The following is a description of a gene set: Any cellular process that depends upon or alters the actin cytoskeleton, that part of the cytoskeleton comprising actin filaments and their associated proteins. studied in species Mus musculus Mouse Gene Set: GOBP_ACTIN_FILAMENT_BASED_PROCESS, and this is the list of marker genes: Magel2, Edn1, Nherf1, Itgb1, Espn, Mical3, Myrip, Rnf207, Prickle4, Wasf2, Kcne5, Mef2a, Was, Myh7b, Tgfb3, Nphs2, Ghrl, Spatc1l, Rflna, Adora1 (adenosine A1 receptor), Arpc5l, Pxn, Hck, Nkx2-5, Scn5a, Epdr1, Hip1, Emp2, Gja5, Rufy3, Neurl2, Zyx, Pdgfa, Shroom2, Lmod2, Cavin3, Mybpc1, Myo18a, Mtor, Rnd1, Pacsin2, Llgl1, Src, Cnn1, Pakap, Gdpd2, Trf (transferrin), Nck1, Add1, Cav3, Enah, Limk1, Serpinf2, Slit2, Sumo1 (NCBI Gene Id 22218), Ikbkb, Lmod3, Casq1, Ctnna3, Septin9, Kcnn2, Myh14, Ezr, Kcnj5, Vangl2, Nf2, Frmd6, Akap13, Bcas3, Myo9b, Sptbn2, Epha3, Brsk2, Myo5c, Cx3cl1, Klhl17, Shroom3, Scin, Pde4d (phosphodiesterase 4D, cAMP specific), Gas2l1, Tmod3, Capzb, Pi4ka, Pls1, Atxn3, Kcnh2, Gmfb, Cfl1, Tpm3, Fgf13, Arhgap35, Dlc1, Anxa1, Actr2 (NCBI Gene Id 66713), Ryr2, Rhod, Gja1, Pdlim3, Nphs1, Lcp1, Actn2, Hsp90b1 (NCBI Gene Id 22027), Abcc9, Tjp1, Elmo3, Arpc5, Kctd13, Hydin, Csf3, Myl2 (myosin, light polypeptide 2, regulatory, cardiac, slow), Fmnl3, Myo18b, Mrtfa (myocardin related transcription factor A), Ptger4, Ppm1e, Msrb1, Tenm1, Mypn, Insrr, Tmsb15l, Nckap1, Abracl, Rangrf, Gm14137, Sorbs1, Specc1, Scn1a, Pick1, Clasp2, Cyria, Vil1, Flnb, Gba2, Coro1b, Camk2d, Ccl26, Pcdh15 (NCBI Gene Id 623239), S100a9, Nup155, Tcap, F2rl1 (F2R like trypsin receptor 1), Capn1, Rnh1, Micall2, Cdc42ep4, Mfn2, Rhoh, Washc2, Kcna5, Sfrp1, Pdlim1, Spag6l, Ppargc1b, Wnt11, Cald1 (caldesmon 1), Farp2, Rap2a, Scn2b, Cryaa, Arhgef17, Slc9a1, Rnd2, Cyfip1, Clec2i, Cit, Arap3, Tpm1, Pycard, Itgb1bp1, Inppl1, Xirp2, Bst1 (bone marrow stromal cell antigen 1), Il1a, Rac3, Cdc42bpb, Spire1, Hcn4, Capza1, Myl6, Tnik (NCBI Gene Id 99639), Kank4, Dpysl3, Rdx, Kcne2, Pard3, Myo7b, Thsd7b, Myo1g, Aqp2, Lats1, Fhod3, Tesk1, Myo1c, Ppfia1, Pdgfb, Trpm4, Alkbh4, Syne2 (NCBI Gene Id 630548), Kras, Foxj1, Limk2, Taok1, Cdc42ep2, Acta1, Hrg, Itpka, Phactr4, Cdh1, Mtpn, Arpc3, Synpo (NCBI Gene Id 77694), Sema5a, S1pr2, Pak3, Wipf1, Cdk5, Frmd5, Cd47, Nck2, Cyrib, Arhgef15, Tmeff2, Abitram, Sptbn5, Dmtn, Tln2, Jup, Frmd3, Capza1b, Eln, Farp1, Rasa1, Cdk5r1, Kcne3, Myo3b, Tnnc1, Pdcl3, Tmsb15b2, Cxadr, Ep300, Sh2b2, Tagln2, Tmod4, Dsg3, Kptn, Pls3, Ppp1r9b, Prkce, Rala, Tmsb10, Clrn1, Ldb3, Kank1, Bmp10, Abra, Dixdc1, Eef2k, Plec, Scn3b, Mylk2, Avil, Myo15a (myosin XVA), Tnf, Tacr1, Tpm3-rs7, Amotl2, Dock2, Eps8, Pik3r2, Washc3, Gsn, Pdlim4, Wasf3, Kit, Naa80, Parvb (parvin, beta), Fscn2, Fam171a1, Arhgap40, Gata4, Pfdn1, Hcls1, Rhpn2, Cldn3, Setd3, Snta1 (NCBI Gene Id 99348), Pam, Actg1, Actn3, Sptbn4, Prkci, Prox1, Asap3, Pecam1 (NCBI Gene Id 97748), Asb2 (ankyrin repeat and SOCS box-containing 2), Lmod1, Myoz2 (NCBI Gene Id 80533), Myo1a, Arhgef10l, Dnaaf11, Ctnna2 (NCBI Gene Id 12548), Ran, Dsg2, Rictor, Pdgfra, Trim27, Mylk3, Sorbs3, Add2 (NCBI Gene Id 72970), Msrb2, S100a10, Plek, Iqgap3, Pak2, Arhgap18, Gas7, Gas2 (NCBI Gene Id 14453), Fermt2, Arfgef1, Nlrp5, Rhobtb2, Srcin1, Wdr1, Rock2, Daam2, Marcks, Kiss1r, Zbed3, Mir129-2, Synpo2l, Tacstd2, Xirp1, Bloc1s6, Sipa1l1, Pafah1b1, Myh8, Uty, Itgb5, Swap70, Cpne6, Myo5a, Cav1, Ccdc88a, Coro2b, Hax1, Myo1b, Gpd1l (NCBI Gene Id 72363), Rtkn, Ehd2, Mef2c, Rab13, Washc5, Glipr1l1, Epha1, Arfip2, Coro1c, Efna5, Fchsd1, Ooep, Epb41l3, Mtss1, Mical2, Mlst8, Bcl6, Nox4, Kcnq1, Nlrp4f, Zeb2, Hdac6, Frmd7, Ccl21f, Grb2, Cnn2, Kcne4, Stau2, Arhgef7, Dnajb6, Casp4, Csrp3, Atp1a2, Fam107a, Sh3gl2, Tyrobp, Cacna1d, Tesk2, Iqgap2, Pfn3, Ermn, Thsd7a, Mical1, Mad2l2, Arhgef19, Fgd1, Phldb2, Jam3, Braf, Fzd10, Cacna1h, Cdc42ep1, Capn3, Dbnl, Plek2, Capza2, Wipf3, Tnnt2, Rhoa, Trpv3, Ang, Nckap1l, Gpm6b, Tgfb2, Icam1, Shank3, Fgr, Frey1, Epb41l2, Aif1, Gas2l3, Arpc1a, Scn1b, Hmcn1, Trpm7, Dstn, Tle6 (transducin-like enhancer of split 6), Prkcd (NCBI Gene Id 52581), Prkd1, Sh3bp1, Sppl2c, Pik3r1, Myo1d, Rhoj, S1pr1, Dlg1, Cul3, Rflnb, Iqsec2, Pclo, Aqp1, Abi3bp, Nedd4l, Ccdc88c, Nf1, Rac1, Wasf1 (WASP family, member 1), Arpc4, Apoa1, Sdc4, Rgs4, Carmil2, Kbtbd13 (NCBI Gene Id 74492), Amotl1, Nrap, Lima1, Acap2, Kcne1, Arf6, Tnnt3, Cavin4, Adgrb1, Pln, C9orf72, Myh11, Limch1, Alms1, Ppm1f, Myo1e, Mrtfb, Actb, Strit1, Lix1l, Stard8, Ptger3, Cttn, Rgcc, Shc1, Ap1ar, Arhgef16, Bcr, Myom2, Baiap2l1, Pdcd6ip, Ift88, Rhov (NCBI Gene Id 228543), Trpv4, Evl, Cacna2d1, Cldn19, Tac1, Flna, Krt8, Actn1 (NCBI Gene Id 94278), Marcksl1, Csf1r, Mybpc3, Jmy, Frmpd4, Kank2, Bcl2, Flii, Gas2l2, Myoc, Pak1, Anln, Rhof, Tnfaip1, Nos1, Arhgef18, Adcy10, Abl2, Phpt1, Kash5, Met, Tpm2, Atp2c1, Dbn1, Ghsr, Rhob, Smap1, 4930544G11Rik, Vasp, Baiap2l2, Cacna1c, Ngef, Rnd3, Mob2, Hip1r, Trpm2, Carmil1, Sh3kbp1, Mybph, Svil, Capn10, Rhobtb1, Syde1, Nedd9, Atp2a2, Arap2, Nrp1 (NCBI Gene Id 270112), Prr5, Krt19, Twf1, Hras, Prkcq, Washc4, Coro7, Esam, Bcar1, Rhoc, Fscn3, Diaph2, Diaph3, Iqgap1, Ssh1, Srf, Inf2, Cracd, Epb41l1, Smad4, Myo7a, Flnc, Limd2, Iqsec1, Nebl (NCBI Gene Id 99452), Gpr65, Fchsd2 (NCBI Gene Id 97424), Ppp1r9a, Myl6b, Gmfg, Wmp, Sun2, Tsc1, Tmod2, Tpm4, Arhgap44, Pkp2, Pmp22, Elmo1, Agap2, Sele, Myo1f, Stmn1, Adprhl1, Smim22, Mink1, Spta1, Pkp3, Abi3, Prex1, Fhl3, Pawr, Ttc8, Siglec15, Kank3, Akap6, Nos1ap, Naa20, Crk (NCBI Gene Id 12928), Rap1gds1, Cdc42 (cell division cycle 42), Spire2, Bag4, Arhgap17, Fmn1, Amot, Fmn2, Sptan1, Cobl, Lpin1, Cap2, Pip5k1a, Plekhh2, Nisch, Prkn, Pik3ca, Catip, Specc1l, Kcnj8, Fat1 (NCBI Gene Id 76752), Atp1a1, Ttc17, Pdlim7, Kcnj2, Fnbp1l, Shroom1 (NCBI Gene Id 71774), Abl1, Rhoq, Myoz1, Dsc2, Ccl21b, Id1, Map3k1, Carmil3, Abr, Capg, Actc1, Sri, Tnnt1, Coro1a, Arap1, Cdc42bpa, Epb41, Arhgap6, Coro6, Atp2a1, Arpin, Ank2, Lurap1, Tnni3, Ptk2b, Epb41l4a, Sirpa, Ect2, Rhog, Plekhg2, Rhpn1 (rhophilin, Rho GTPase binding protein 1), Slc4a2, Tlr2, Whamm, Tgfbr1, Stard13, Mkks, Washc1, Myh9, Myadm, Dsp, Luzp1, Smad3, Cyfip2, Aif1l, Ptk7, Hdac2 (histone deacetylase 2), Srgap2, Cd2ap, Klhl41 (kelch-like 41), Cln3, Arhgef10, Abi2, Fhod1, Ophn1, Arpc1b, Myom3, Tmsb4x, Myo3a, Ccr7, Bst2, Trim32, Ccn2, Tln1, Calr, Dapk3, Arhgef26, Ilk, Elmo2, Mkln1, Rhou, Fhdc1, Samd14, Pfn5, Diaph1, Cdk10, Myo1h, Ccl27a, Arfip1, Cdc42ep5, Cflar, Cap1, Synpo2, Ccl21a, Arhgap12, Mybpc2, Snx9 (sorting nexin 9), Myo19, Arrb1, Myl9, Kcnc3, Actr3, Myo5b, Espnl, Shtn1, Fgf7, Myo6, Twf2, Pfn1, Parvg, Ssh3 (NCBI Gene Id 245857), Taok2 (TAO kinase 2), Fmnl2, Cacnb2 (calcium channel, voltage-dependent, beta 2 subunit), Scn4b (NCBI Gene Id 399548), Dnm2, Ccl24, Cdc42bpg, Grhl3 (grainyhead like transcription factor 3), Adrb1, Capza3, Shroom4, Gm28729 (NCBI Gene Id 102635744), Racgap1, Baiap2, Lrp1, Pdgfrb, Pdlim2, Epha5, Myom1, Ttn, Parva, Add3, Tbck, Alox15, Actn4, Fscn1, Ccl21e, Antxr1, Grid2ip, Iqsec3, Palld, Llgl2, Sptbn1, Pdpn, Fmnl1, Neb, Tgfb1, Pdxp, Cttnbp2, Pfn2, Daam1, Crhr2, Fer, Bin1, Kif3a, Arpc2, Wasl, Sh3pxd2b, Six4, Akap9, Arhgef2, Ccl11, Dnai3, Arhgef5, Casq2, Pgm5, Khdc3, Rock1, Ccl21d, Sgcd, Odam, Akap11, Cnn3, Pof1b, Epb41l4b, Cdc42ep3, Vill, Bbs4, Phactr2, Cgnl1, Myh10, Strip1, Kcnd3, Myh7, Wnt4, Phactr1, Kirrel1, Myh6, Tmod1, Arf1 (ADP-ribosylation factor 1), Sh3d21, Sptb, Rapgef3, Itgb3, Dtnbp1 (NCBI Gene Id 94245), Csrp1, Arhgap25, Celsr1, Epb41l5, F11r, Nuak2, Fxyd1, Auts2, Phactr3, Tagln3, Ankrd23, Csrp2, Lpar1, Brk1, Prkar1a, Clasp1, Qki, Acta2, Pacsin1, Cfl2 (NCBI Gene Id 12632), Ush1c, Ssh2, Ptpn1, Fgf10, Rac2 (NCBI Gene Id 19354), Stc1, Inpp5k, 3425401B19Rik, Shank1, Pdlim5, Cotl1, Arhgap28